Given this list of marker genes APOC2, SAMHD1, APOA4, DEFA5, ZEB1, BCAT2, IRF7, SLFN12, IRGM, DGKA, ITLN1, PTPN22, DPEP1, RBP2, SLC2A2, ADA, LTB, PSMB9, GUCA2B, IFIT1B, TFF3, HLA-B, CRIP1, TAP1, PSMB8, OGFR, GGT1, GNB1, ZG16, ABCG2, IGHM, CCL8, MS4A1, here is a description of the gene set: BACKGROUND AND AIMS: The gastrointestinal trefoil factor family (TFF1, TFF2, TFF3) peptides are considered to play an important role in maintaining the integrity of the mucosa. The physiological role of TFF2 in the protection of the GI tract was investigated in TFF2 deficiency. METHODS: TFF2-/- mice were generated and differential expression of various genes was assessed by using a mouse expression microarray, quantitative real time PCR, Northern blots or immunohistochemistry. RESULTS: On an mRNA level we found 128 differentially expressed genes. We observed modulation of a number of crucial genes involved in innate and adaptive immunity in the TFF2-/- mice. Expression of proteasomal subunits genes (LMP2, LMP7 and PSMB5) involved in the MHC class I presentation pathway were modulated indicating the formation of immunoproteasomes improving antigen presentation. Expression of one subunit of a transporter (TAP1) responsible for importing degraded antigens into ER was increased, similarly to the BAG2 gene that modulates chaperone activity in ER helping proper loading on MHC class I molecules. Several mouse defensin (cryptdin) genes coding important intestinal microbicidal proteins were up-regulated as a consequence of TFF2 deficiency. Normally moderate expression of TFF3 was highly increased in stomach. studied in species Mus musculus Human Gene Set: BAUS_TFF2_TARGETS_UP from publication Baus-Loncar M, Schmid J, Lalani el-N, Rosewell I, Goodlad RA, Stamp GW, Blin N, Kayademir T (PMID 16121031) Genes up-regulated in pyloric atrium with knockout of TFF2.